The following is a description of a gene set: Human Gene Set: GOBP_REGULATION_OF_CELL_MIGRATION_INVOLVED_IN_SPROUTING_ANGIOGENESIS Any process that modulates the frequency, rate or extent of cell migration involved in sprouting angiogenesis. Cell migration involved in sprouting angiogenesis is the orderly movement of endothelial cells into the extracellular matrix in order to form new blood vessels contributing to the process of sprouting angiogenesis. species: Homo sapiens, and this is the list of marker genes: SRPX2, GREM1, KDR, HDAC5, MAP2K5, PDCD10, MIR495, MIR16-1, PIK3C2A (phosphatidylinositol-4-phosphate 3-kinase catalytic subunit type 2 alpha), MIR196A1, MIR10A, MIR146A, NUS1, MIR199A1, FGFBP1, MIR150, MMRN2, TBXA2R, THBS1, CIB1, HDAC9, MIR424, MIR31, HDAC7 (histone deacetylase 7), MIR494, MIR22, ITGB1BP1, CARD10, FGF2, MIR497, MIR885, MIR10B, MIR410, VEGFA, RHOA, MIR2355, MIR487B, MIR503, MIR101-1, MIR126, STARD13, MIR206, SPRED1, MIR200C, DLL4, GATA2, MIR27A, MIR320A, MIR23A, MIR149, MIR205, MIR19B1, MIR26A1, MIR15A, MIR132, HMOX1, MIR221, MIR329-1, MIR20A, MIR29C, MIR296, PTGS2, MIRLET7A1, NRP1, PLK2, TGFBR3, MIR361 (NCBI Gene Id 494323), MIRLET7F1, MIR483, NOTCH1, ANXA1, MEOX2, RHOJ, ABL1, AKT3, KLF4, NR2E1, MIR193A, MIR27B, MMRN1, JCAD, FOXC2 (forkhead box C2)